The following is a description of a gene set: Mouse Gene Set: MIR_7079_3P from publication Chen Y, Wang X (PMID 31504780) Genes predicted to be targets of miRBase v22 microRNA mmu_miR_7079_3p in miRDB v6.0 with MirTarget v4 prediction scores > 80 (high confidence targets). species: Mus musculus, and this is the list of marker genes: Vps9d1, Zfp781b, Flg2, Rnf169, Tomm22, Itm2a, Tgif2lx2, Myocd, Rhoa, Grm7, Gpatch2l, 4930544G11Rik, Mat2a, Dgkh, Kcmf1, Trim2, Lpp, Tmtc4, Amer2, Ccdc3, Nuak1, Hdhd2, Rabep1, Rbm27, Adamts12, Serpinb9, Zfp874a, Cep350, Trib2, Folh1, Clca2, Tenm3, Nrxn1, Sh3tc2, Mmd2, P2rx2, Hspd1, Scn1a, Cwf19l1, Ssr3, Peli2, Cd200r1 (NCBI Gene Id 57781), Aak1, 9430038I01Rik, Mcmbp, Cemip (NCBI Gene Id 83495), Nefl, Atxn7l3b, Wapl, Cotl1, Slc17a3, Ebf3, Lypd1, Vezf1, Nfat5, Rbbp6, Ppa1, Chd6, Glt28d2 (NCBI Gene Id 320302), Evi5, Fam13c, Aldoc, Zfp780b, Mfsd9, Pak2, Pyroxd1, Zkscan1, Ccdc174, Rnf181, Zfp9, Sipa1l2, Stat6, Prkag2, Prkca, Tgif2lx1, Prkcq, Armc1, Pigm, Pakap, Tmem47, Jph1, Ciapin1, Srpk2, Kif18a, Ccr5 (NCBI Gene Id 235693), Klhdc8a, Map2k7, Bcl9l, Hsd17b6, Zfp943, Zbtb26, Guca2a, Pter, Hoxd1, Tyr, Prkce, Tifa, Ccdc92b, Klhl25, Dbndd2 (NCBI Gene Id 99295), Cnr1, Dnah9, Inafm1, Gtsf2